Given this list of marker genes Coro1c, Fer (NCBI Gene Id 80679), Pip5k1a, Fndc3b, Hyal2, Tns1, Akap12, Dmtn, Apc, Ptk2, Lamtor2, Tmem201 (transmembrane protein 201), Macir, Cripto, Gna13, Itga11, Fgfr1, Clasp2, Actr3, Acta2, Cln3, Arid5b, Prr5l, Rac1, Pak1, Ilk (NCBI Gene Id 16202), Bag4, Appl1, 2610005L07Rik, Gna12, Tfap2a, Pdlim1, Aqp1, Plec, Zeb2, Itgb1bp1, Rcc2, Adipor2, Ddr2, Tgfb1, Spag6l, Rffl, Fam114a1, Uts2, Nherf1, Sgpl1, Ager, Iqgap1, Zfp640, Zfand5, Ccn3 (cellular communication network factor 3), Pmp22, Mta2, Wdpcp, Has1, Pdgfb, Tsc2, Thbs1, Braf, Prkce, Schip1, Cygb (NCBI Gene Id 78886), Appl2, Itgb3, Itgb1, Mmp1a, Akt1, Fut8, Pml, Fgf2, Sdc4, Pak3, Cd248, Arhgap4, Slc8a1, here is a description of the gene set: Cell migration that is accomplished by extension and retraction of a fibroblast pseudopodium. A fibroblast is a connective tissue cell which secretes an extracellular matrix rich in collagen and other macromolecules. species: Mus musculus Mouse Gene Set: GOBP_FIBROBLAST_MIGRATION